The following is a description of a gene set: species: Homo sapiens Keratan sulfate (KS) (a glycosaminoglycan, GAG) is a linear polysaccharide that consists of the repeating disaccharide unit GlcNAc-Gal (N-acetylglucosamine-galactose). KS can perform a structural function and is found in bone, cartilage and the cornea. In joints, it also acts as a shock absorber due to its highly hydrated nature. There are several classes of KS, KSI, II and III. KSI is N-linked to asparagine (Asn) residues in the core protein and is predominantly found in the cornea. KSII is O-linked to serine (Ser) or Thr (threonine) residues in the core protein and is found predominantly in cartilage linked to the protein aggrecan, forming the most abundant proteoglycan in cartilage. A third class of KS, KSIII, are proteoglycans in the brain. KSIII chains are linked to Ser/Thr residues in the core protein via mannose.<br><br>Normally, the body degrades GAGs as a natural turnover. Defects in the degradative enzymes cause the autosomal recessive mucopolysaccharide storage disease Morquio's syndrome (also called mucopolysaccharidosis IV). This involves the build up of KS in lysosomes, manifesting clinically as skeletal, dental and corneal abnormalities. part of: Glycosaminoglycan metabolism Reactome Pathway: Keratan sulfate/keratin metabolism, and this is the list of marker genes: B4GALT3, CHST6, CHST5, GLB1L2, SLC35D2, CHST1, B3GNT3, ACAN, GLB1L3, ST3GAL4, PRELP (proline and arginine rich end leucine rich repeat protein), OMD, LUM, ST3GAL1, B4GALT4, HEXA, CHST3, GLB1L, B4GALT5, ST3GAL2, KERA, B4GALT2, B4GAT1, B4GALT6, B3GNT2, OGN, B3GNT7, B3GNT4, GNS, GALNS, B4GALT1, ST3GAL3, ST3GAL6, CHST2, GLB1, FMOD (fibromodulin), HEXB